Given this list of marker genes HSP90B1, HSP90AA1, TMEM95, ADAM21, OPN4, PKDREJ, LYZL6, HSPD1, EPPIN, RHO, ADAM20, ADAM29, ABHD2, ADAM30, CCR6, here is a description of the gene set: Human Gene Set: GOCC_SPERM_PLASMA_MEMBRANE A plasma membrane that is part of a sperm cell. studied in species Homo sapiens